Given this list of marker genes MAPKAPK5, CALCOCO1, CTDSP2, MAP2K1, XPC, EZH1, RUVBL2, MYCL, XPO7, TOGARAM1, CXCR4, TADA3, DNAJC16, SET, LRPPRC, MOGS (NCBI Gene Id 7841), ANP32B, GATA6, IFNGR1, MMS19, POLRMT, MAEA, MAPK14, UBE4B, MAN2A2, ACP1 (NCBI Gene Id 52), PLXND1 (NCBI Gene Id 23652), ZAP70, SYCP2, RGS2, TMEM41B (NCBI Gene Id 440026), ST3GAL6, ZNF318, DAP3, PPP1CC, MXD4, KHDC4 (KH domain containing 4, pre-mRNA splicing factor), ARHGAP29, FMNL1, CEBPG, BTG1, ALDH3B1, SLF2, AASDHPPT (aminoadipate-semialdehyde dehydrogenase-phosphopantetheinyl transferase), GLB1, SELENOW, STS, SIPA1L3, STK38L, KLF7, HNRNPA0, SMARCC1, ARID3A, PDCD6, KLHL21, PARK7, GNA11, CEBPA, ZNHIT3, WDTC1, GCSH, RXRA, RNF113A, TRAF3, BLCAP, TGFBR2, PTP4A2, SNAPC4, NAT9, ZBTB5, CD81, PCGF1, LUC7L3, MYBPC3, MAST3, DCAF1, REEP5, SCARB1, DBP, DDIT4, RYBP, AKR7A2, SMARCC2, MAP3K14, NCAPD2, RPP40, FES, XPOT, ITPR1, HMGB2, RASSF2, MAPKAP1, ALDH9A1, NARS1, CREBL2, TNRC6B, FOXO4, FRAT2, RSBN1, MARF1, PIGC, BTG2, FAM13A, NPRL2, PATZ1, SAP30, EHMT2, PAWR, SPTSSA, C2CD2, GOLGA1, ATG2A (NCBI Gene Id 23130), CCNG2, TTC3, PURA, CIAPIN1, HAGH, AKAP10, RNMT, TFAP2A, ACSM3, RNF44, METAP1, CYB561D2, MBD4, DPH2, CBX5, ZBTB18, IDS, MCAT, ARHGAP35, NCOR2, OXA1L, ZKSCAN1, WDR18, UBXN7, H1-10, DOK1, TMEM243, STARD7, IFFO1, HMGN1, ARAP1, SIRPA, CCNH, RMND5A, FAM53B (family with sequence similarity 53 member B), ST20, ATP2A3, PTGS1, PPIE, FAM216A, STAT5B, SLC16A6, WBP1L, PRCC, CXCL3, DHX29, NDUFB7, MEGF9 (multiple EGF like domains 9), OSMR, AQR, ATXN7L3B, POLR3C, VWA5A, FAM50B, EPRS1, API5, UGT2B15, MDH1 (NCBI Gene Id 4190), ZNF688, ZNF211, GLT8D1, PDHB, RPRD2, ARHGAP45, PFAS, DUSP10, MNT, RALBP1, PPP1R7, FZD1, SGSM3, LIMK1 (LIM domain kinase 1), HMBS, YJU2, ZHX3, CCDC93, SNAPC5, CYB5R1, ZBTB14, MRFAP1L1, SF3A1, BRD8, VPS41, CXCL2, UBAC1, FARSA, ALG8, SRPRA, here is a description of the gene set: Human Gene Set: GSE7509_DC_VS_MONOCYTE_WITH_FCGRIIB_STIM_UP Genes up-regulated in response to anti-FcgRIIB: dendritic cells versus monocytes. from publication Dhodapkar KM, Banerjee D, Connolly J, Kukreja A, Matayeva E, Veri MC, Ravetch JV, Steinman RM, Dhodapkar MV (PMID 17502666) studied in species Homo sapiens The ability of dendritic cells (DCs) to activate immunity is linked to their maturation status. In prior studies we have shown that selective antibody-mediated blockade of inhibitory FcgRIIB receptor on human DCs in the presence of activating immunoglobulin (Ig) ligands leads to DC maturation and enhanced immunity to antibody-coated tumor cells. Here we show that Fcg receptor (FcgR) mediated activation of human monocytes and monocyte-derived DCs is associated with a distinct gene expression pattern, including several inflammation associated chemokines as well as type 1 interferon (IFN) response genes including the activation of signal transducer and activator of transcription 1 (STAT1).